Given this list of marker genes NOP56, RRP9, SNU13, FBL, NOP58, FBLL1, here is a description of the gene set: A ribonucleoprotein complex consisting of a box C/D type snRNA and three (Archaea) or four (Eukaryotes) core proteins that have diverse functions, including site-specific methylation of rRNA and processing rRNA. Human Gene Set: GOCC_BOX_C_D_RNP_COMPLEX studied in species Homo sapiens